Given this list of marker genes HNRNPU, NKAPD1, TRPM2, RGMA, MARCHF6, ATP8B5P, SALL1, VASN, PGRMC2, MARK2, SMARCD1, MYO18A, ZBTB41, DOLPP1, PHF6, PHC2, PPTC7 (protein phosphatase targeting COQ7), SNX24, ARL2, CADM1, MLLT10, GPR85, RIMS3, APOBEC2, NUFIP2 (NCBI Gene Id 57532), FAM53C, PCDH7, PIM1, HSD17B8, NRP1, GRAMD2B, KPNA3, QKI, CRY2, KCNJ14, BRPF1, ARVCF, SLC7A8, JAZF1, CPSF4, POU4F2, NRIP1, CBL, CDC42SE1, ARPP21, UBE2R2 (ubiquitin conjugating enzyme E2 R2), NAA15, SORCS1, LY6E, PLAGL2, BAZ2A, CACNA1I, VEZT, CSF1, IPO7, UMOD (uromodulin), IQSEC2, KIFC3, ZNF609, CD247, BACE1, HAPSTR1, TAF15, SPTBN2, GOLGA2P10, RGL4, DOK4, RAP1GAP2, JMJD8, MINK1, WDTC1, EGLN2, NAA50, ARPC5L, HERC2P9, IPO11, GANC, CELSR2, YAF2, SMARCC1, AFF2, REPIN1, PICK1 (protein interacting with PRKCA 1), MB21D2, HMGN3, TGOLN2, OXR1, IGDCC3, SLC16A3, TFAP2C, LARP1, SDAD1, RASSF5, LRATD2, USP46, SEC24C, RETREG2, ITCH, SNURF, RNF40, NCKIPSD, MID1, SIGMAR1, MRM2, ACLY, TMEM248, GNAI2, PPM1A, CRKL, ATP2B4 (NCBI Gene Id 54594), SRGAP3, CD47 (CD47 molecule), DOCK9, FBXW5, LHX6, TMED10, TCN2, ZMYM6, RALGAPB, HMG20A, ARID5A, CAMTA1, ING1, FOXO4, PPME1, SNHG11, MAPK1IP1L, PELI3 (pellino E3 ubiquitin protein ligase family member 3), ALKBH6, BACE2, CPEB4, PLCB4, UGGT2, PDRG1, TBC1D10B, TRAPPC3, PTER, CELF2, PCDH20, HDLBP, BTBD1, MYEF2, RTF1, PAPPA, SRSF1, CLASP1, RAB35, PAFAH1B1, RAD54B, ACVR1B, EIF4G1, TUBA4B, FAM133B, ESRRA, PARP16 (NCBI Gene Id 54956), HOXC4, EZH1, LUZP1, NRXN3 (NCBI Gene Id 9369), HTR2C, RTN2, SGCD, ANO7, MED19, TWF1, MAPT, GRM7, PIK3AP1 (phosphoinositide-3-kinase adaptor protein 1), LSM12, PANK2, RAPGEFL1, MOBP, SLC25A3, PCDH17, PARP6, NPTXR, TRPS1, RNF44, CERS1, HAGH, NMB, ZBTB39 (NCBI Gene Id 9880), DNAJB6, GALNT18, PIANP, IFT46, LDOC1, ZFAND3, YWHAZ, CHMP4B, ADORA2A, ABLIM3, CDIPT, SFSWAP, DUSP15, LMOD1, PGF, ACP4, DGKZ, KMT5A, IL17RC, ARMC5, FNDC5, ZBTB20, HDGF, CXXC5, TRIP10, GRIN1, PURB, AMMECR1L, ZHX3, PANK1, BCL11A, NDUFAF5, TBC1D25, SYNE4, TMEM258, ZFAND6, RAB15, GALNT7 (polypeptide N-acetylgalactosaminyltransferase 7), KLC2, NEDD4L, FZD7, ANKS1B (ankyrin repeat and sterile alpha motif domain containing 1B), MROH7, TBL1XR1, ERLIN2, RAB4B, ARHGAP31, MARK4, PARD6G, ATXN7L1, NBL1, SOCS7, SNX12, SEPTIN4, RIMS4, SHISA6, MOG, SSBP3, ZIC1, RAB14, here is a description of the gene set: species: Homo sapiens Human Gene Set: CCTGCTG_MIR214 Genes having at least one occurence of the motif CCTGCTG in their 3' untranslated region. The motif represents putative target (that is, seed match) of human mature miRNA hsa-miR-214 (v7.1 miRBase).